The following is a description of a gene set: Human Gene Set: HP_ABNORMALITY_OF_THE_DISTAL_PHALANX_OF_THE_3RD_FINGER species: Homo sapiens Abnormality of the distal phalanx of the 3rd finger, and this is the list of marker genes: GNAS, TWIST1 (NCBI Gene Id 7967), FGFR2, NSDHL, COL2A1